Given this list of marker genes IRS2, IRS1, ABCD2, CPT1A, PPARA, PLIN5, MTLN, AKT2, ABCD1, TWIST1, here is a description of the gene set: studied in species Homo sapiens Human Gene Set: GOBP_POSITIVE_REGULATION_OF_FATTY_ACID_BETA_OXIDATION Any process that activates or increases the frequency, rate or extent of fatty acid beta-oxidation.